Given this list of marker genes POU6F2, SRCIN1, ZNF664, PDHA2, TIMP3 (NCBI Gene Id 7078), TYW1B, TMEM176A, ZSCAN12, PDE2A, SPACA4, RIMS3, SMURF1, OTP, PYCARD, SERPINE1, WNT6, XAGE3, ZRANB1, SERPIND1, PRSS36, PDZD7, ST6GALNAC3, PHF21B, ZNF827, RNF222, TMPRSS3, TMEM72, PHB1, ZNF628, VWF, SESN2, PSORS1C1, SFT2D3, SYTL3, ZNF714, TBC1D24, TTC23L, ZNF527, RAB5C, SLC26A8, ZNF746, ZBTB43, SCEL, CPLANE2, TEX13B, ZNF341, VSTM1, UROS, PPP3R2, TAS2R46, THBD, PLEKHB2, TPRG1, PNLIPRP3, RPS6, PFKFB1, TMEM176B, PRSS30P, PDGFRA, PHTF2, RXYLT1, P2RX3, PRPF8, VWA2, SQLE, ZNF93, POM121L12, SNX5, UAP1L1, PTH, SH3BP5, SRSF12, SHARPIN, TBR1, TMEM9B, RPL28, RIMS1, PRRG4, ZNF773, TNFRSF13B, ZNF879, VWC2L, PRSS27, TMEM212, SUSD2, YIPF5, VSTM2L, SYNJ2BP, TSPAN13, OSTN, PNPLA4, YAP1, SLC5A8, PWWP2A, RPL27, PKN1, PHF19 (PHD finger protein 19), RXRA, SLC9A4, SLC37A3, EMC6, PGP, MRM3, ZBTB34, TKT, STAR, RMND1, TMEM237 (transmembrane protein 237), SCARNA14, TM4SF20, PITPNM3, PNKP, SLC9C2, SNAP91, PSMA6, TMEM200A, ZFPL1, SCML2 (Scm polycomb group protein like 2), SLCO3A1, PEG10, VPREB3, RPN1, PPP4C, ZNF70, TSPAN12, XDH, RRAGD, TOP1MT, SUMO3, SLC8A2, RPS5, SETD5, CCN5, POLR2A, PSMB7, SNORA54, STK17A, SLC35F4, RBP2, ZNF705A, SLC39A1, ZDHHC19, SLC25A3, RHBDF1, WNT8B (NCBI Gene Id 7479), PPP1R13L, RIN1, PLK5, RFX5, UBR7, VAT1L, PLBD2, TLX2, SLC14A2, THAP9, SERPINA6, SIAH1, PRRG3, TMEM69, URB2, PKDCC, UCN3, TXNL1, SPAG7, TCAP, ZNRD2 (NCBI Gene Id 10534), PDXK, TMEM100, RUVBL1, POU2F2, TULP1, USHBP1, SP3, SHCBP1L, RIC8B, REG1A, PSMA1, TNFRSF19, TMEM132E, RBP5, STX8, SNX15, PSG2, SNORD115-41, SCHIP1, PLBD1, RHOF, SPATS2, TNIP2, ZBTB22, ROR2, SNORA51, TMEM231, ZNF530, RAPGEFL1, ZNF473, SH3TC2, here is a description of the gene set: from publication Borjesson DL, Kobayashi SD, Whitney AR, Voyich JM, Argue CM, Deleo FR (PMID 15879137) Polymorphonuclear leukocytes (PMNs) were obtained from healthy individuals in accordance with protocols approved by the Institutional Review Board for Human Subjects at the University of Minnesota and the National Institute of Allergy and Infectious Diseases. PMNs (107) were combined on ice with live S. aureus (108) or with live or heat-killed A. phagocytophilum (bacteria isolated from 5x106 infected HL60 cells for a ratio of 1 infected HL60 cell: 2 PMNs, ~ 5-20 A. phagocytophilum: PMN) in wells of a 12-well tissue culture plate (pre-coated with 20% autologous normal human serum). Unstimulated control assays received either buffer (for S. aureus comparisons) or clarified HL60 lysate (for A. phagocytophilum comparisons). Plates were centrifuged at 350 x g for 8 min at 4oC to synchronize phagocytosis and incubated at 37 deg. C in a CO2 incubator for the indicated times. At the indicated times, tissue culture medium was aspirated from the plate and PMNs were lysed directly with RLT buffer (Qiagen, Valencia, CA). Purification of PMN RNA and subsequent preparation of labeled cRNA target was performed as described in Methods. Labeling of samples, hybridization of cRNA with HU133A oligonucleotide arrays (Affymetrix, Santa Clara, CA), and scanning were performed according to standard Affymetrix protocols ( http://www.affymetrix.com/pdf/expression_manual.pdf ). Experiments were performed in triplicate, using PMNs from three healthy individuals for each treatment. Genes down-regulated in polymorphonuclear leukocytes (24h) infection by A. phagocytophilum: heat killed versus live bacteria. Human Gene Set: GSE2405_HEAT_KILLED_VS_LIVE_A_PHAGOCYTOPHILUM_STIM_NEUTROPHIL_24H_DN studied in species Homo sapiens